Given this list of marker genes Alx4, Snai1, Intu, Elovl1, Cd109, Lamc1, Eda, Rbpj, Fa2h, Norad, Dsg4, Flg2, Notch1, Cldn4, Wnt10a, Zfp750, Ppard, Apcdd1, Trpc4ap, Edar, Mfsd12, Nfkbiz, Grhl1, Trps1, Foxe1, Wnt10b, Lrp4, Sos1, Runx3, Gsdma3, Inhba, Wnt5a, Zdhhc21, Gata6, Sav1, Barx2, Nsdhl, Flg, Tradd, Celsr1, Alox12, Tmem79, Egfr, Vangl2, Dnase1l2, Lgr5, Ncor1, Krt28, Rela, Bcl2, Gnas, Fuz, Kprp, Psen2, Krt25, Gorab, Naglu, Ctsl, Tmprss11f, Foxq1, Pkp3, Edaradd, Acvr1b, Shh, Sox21, Krtap21-1, Klf4, Tmprss13, Cldn1, Stmn1, Cdh3, Lsr, Cysrt1, Gli2, Dlx3, Atp7a, Hrnr, Ptgs2, Fgfr2, Psen1, Pias4, Plec, Msx2, Stard7, Ngfr, Krt71, Ercc2, Prss8, Fst, Fgf10, Runx1, Ldb2 (NCBI Gene Id 16827), Ldb1, Dkk1, Dicer1, Trpv1, Fzd3, Dbi, Numa1, Smad4, Trp63, Abca12, Slc39a7, Lhx2, Foxn1, Cdh1, Pum2 (NCBI Gene Id 80913), Pdgfa, Srf, Foxi3, Tnfrsf19, Nf1, Hpse, Lama5, Lgr4, Hdac2, Cldn13, Gal, Myo5a, Krtap6-2, Il18, Met, Dsc1, Tgfb2, Kdf1, Krt1, Smo, Ext1, Tfap2c, Ctnnb1 (catenin beta 1), Krt17, Tnf, Aloxe3 (NCBI Gene Id 23801), Grhl3, Dll1, Nsun2, Gak, Fgf7, Zmpste24, Hdac3, Mreg, Krt16, Sox18, Hoxc13, Akt1, Apc, Mysm1, Alox12b, Fzd6, Nom1, Igfbp5, Sfn, Sostdc1, Col6a1, Ap3b1, Krt27, Pnpla1, Pla2g10, Fermt1, Gba1, Sox9, Lncpint, Dkk4, Ugcg, Ncor2, Hdac1, Cyp26b1, here is a description of the gene set: The process whose specific outcome is the progression of the skin epidermis over time, from its formation to the mature structure. Mouse Gene Set: GOBP_SKIN_EPIDERMIS_DEVELOPMENT species: Mus musculus